Given this list of marker genes POLR2L, TAF1C, POLR1A, POLR2E, CDK7, POLR1H, GTF2H5, GTF2H3, POLR1C, POLR1B, ERCC2, POLR2H (RNA polymerase II, I and III subunit H), POLR1D, POLR1F, GTF2H2 (general transcription factor IIH subunit 2), CAVIN1, UBTF (NCBI Gene Id 7343), POLR2K, MNAT1, GTF2H4, GTF2H1, POLR1G, POLR2F, ERCC3, TAF1D, TAF1A, POLR1E, CCNH, TTF1, TBP, TAF1B (TATA-box binding protein associated factor, RNA polymerase I subunit B), here is a description of the gene set: RNA Polymerase I Transcription Termination species: Homo sapiens Human Gene Set: REACTOME_RNA_POLYMERASE_I_TRANSCRIPTION_TERMINATION